Given this list of marker genes CALCA, GLP2R, VIPR2, GLP1R, GNG13, GNG2, ADGRE3, SCTR, SCT, GNG5, WNT4, FZD5, PTHLH, ADCYAP1R1, ADGRE1, WNT9A, FZD4, GNAS, RAMP2, GNB2, WNT7B, FZD2, WNT2, GCGR, CD55, GNG11, FZD9, GNB4, ADGRE2, GNG10, GNG3, ADM2, GHRH, WNT10B, GCG, WNT3A, UCN, ADM, PTH2R, SMO, CALCR (calcitonin receptor), GNGT1, IHH, GNG4, FZD8, PTH, FZD6, GNG12, GNGT2, WNT8B, GNB1, WNT7A, ADCYAP1, WNT16, FZD3, RAMP1, WNT8A, CRHR2, FZD10, GNB5, GNG7, CALCRL, CALCB, WNT5A, GNB3, CRHBP, GNG8, VIP, PTCH2, RAMP3, FZD7, CRH, VIPR1, WNT3, IAPP, PTCH1, WNT11, PTH2, WNT2B, WNT9B, GIPR, UCN3, WNT1, UCN2, ADGRE5, WNT6, FZD1, CRHR1, GHRHR, PTH1R, DHH, SHH, GIP, WNT10A, here is a description of the gene set: species: Homo sapiens part of: GPCR ligand binding This family is known as Family B (secretin-receptor family, family 2) G-protein-coupled receptors. Family B GPCRs include secretin, calcitonin, parathyroid hormone/parathyroid hormone-related peptides and vasoactive intestinal peptide receptors; all of which activate adenylyl cyclase and the phosphatidyl-inositol-calcium pathway (Harmar AJ, 2001). Reactome Pathway: Class B/2 (Secretin family receptors)